The following is a description of a gene set: Genes up-regulated in comparison of dendritic cells (DC) stimulated with LPS (TLR4 agonist) at 24 h versus DC cells stimulated with CpG DNA (TLR9 agonist) at 24 h. Human Gene Set: GSE17721_LPS_VS_CPG_24H_BMDC_UP species: Homo sapiens mouse primary BMDCs were stimulated with tlr ligands and gene expression changes were profiled on Affymetrix arrays from publication Amit I, Garber M, Chevrier N, Leite AP, Donner Y, Eisenhaure T, Guttman M, Grenier JK, Li W, Zuk O, Schubert LA, Birditt B, Shay T, Goren A, Zhang X, Smith Z, Deering R, McDonald RC, Cabili M, Bernstein BE, Rinn JL, Meissner A, Root DE, Hacohen N, Regev A (PMID 19729616), and this is the list of marker genes: TGFB1I1, AGK, CXCL11, GPAA1, SBDS, GCLM, FAM162A, IL17D, AFG1L, KCNQ1 (potassium voltage-gated channel subfamily Q member 1), PLEKHF2, REG1B, MRPL34, TSPAN13, GBP2, ZBTB8A, GLMP, METTL17, DYNLT1, TRIM69, CCDC59, SDHAF1, SERPINE1, PAFAH1B3, MVB12A, RAP2A, CHST4, MOCS2, OTUD7B, RAMAC, RND2, SPDL1, BCDIN3D, SLC1A2, SURF1, NHERF1, LMO1, RSAD2, ARL6, NDUFAF3, DGCR8, VAMP8, BMI1, NDUFA6, CA10, HSPA14, ADGRA3, BEST2, FXYD5, CZIB, FOSL2, STAT1, MKNK2 (NCBI Gene Id 2872), MTMR6, GPR89B, SLC39A8, MRPS30, KCNQ2, CCR1, SEMA7A, SENP1, SLC37A2, CLBA1, EAPP, KRT2, CRLF3, DNMT3L, NUDT19, STXBP1, KCNK2, TNK1, TPPP3 (tubulin polymerization promoting protein family member 3), SMOX, DYM, ENTREP3, WDR86, UBA7, TFPT, IL1A, MESP1, P2RY12, S100G, AOPEP, ADI1, TRPT1, DTNB, TOR1AIP2, PITX3, CCNB1IP1, MPDU1, CRIP1 (NCBI Gene Id 1396), TRAPPC5, NCAM1, PHF5A (NCBI Gene Id 84844), TSSK2, CUX1, RAB4B, CIDEA, GGH, PGLYRP1, SLC25A35, BBS9, NUDCD1, GALNT16, TUBA1A, NDUFA10, MFSD4B, SSBP2, ACSS1, ARID5A, PARP16, CNTN3, AKR1D1, NAA38, ARPC3, KCNU1, LY6G6D, LYVE1, CFI, BRIX1, BCL2L14, EPAS1, VWA5A, SIX1, CSNK2A2, TIMP4, GPSM1, ZC3H14, FABP2, TFCP2L1, DTNBP1, SLAMF8, MFAP1, ARHGDIG, VTA1, VRK3, SCAND1, PBRM1 (NCBI Gene Id 55292), EHBP1, TNFRSF9, NRBP1, QTRT2, PGAP6, GCOM1, CWC22, SUMO3, RAB34, CHCHD3 (NCBI Gene Id 54927), FBXO6, P2RX4, EPN3, SLC41A1, HMBS (NCBI Gene Id 5448), EMID1, GBP6, CXCL16, TIMP1, TDRD7, ZNHIT1, EIF2B1, HIGD1B, C12orf57, UQCC3, CYLC1, TTPA, STAT2, WDTC1, NOXO1, IFIT2, SUB1, PHYH, ARX, LSR, NFIX, LTC4S, STAP2 (NCBI Gene Id 55620), SLC46A1, TNFAIP8L1, KCNAB1, ACD, TLX2, UQCC1, ZNF142, BRMS1, CNMD, GDA, BCL11B, CEP164, LGALS8, PTGDR2, TCEA3, ENKD1, PRPSAP2, EFNB2, ZNHIT3, IL15, TNP2, NOP16, AUH